The following is a description of a gene set: studied in species Mus musculus Mouse Gene Set: GOBP_NEURAL_PLATE_DEVELOPMENT The process whose specific outcome is the progression of the neural plate over time, from its formation to the mature structure. The neural plate is a flat, thickened layer of ectodermal cells. The underlying dorsal mesoderm signals the ectodermal cells above it to elongate into columnar neural plate cells. The neural plate subsequently develops into the neural tube, which gives rise to the central nervous system., and this is the list of marker genes: Ctnnb1, Zic3, Ptch1, T, Epb41l5, Dvl1, Fgf8, Htt, Zfp568, Nog, C2cd3, Dvl2, Vangl2, Zic2